The following is a description of a gene set: species: Homo sapiens In otosclerosis, a callus of bone accumulates on the stapes creating a partial fixation. This limits the movement of the stapes bone, which results in hearing loss. Human Gene Set: HP_OTOSCLEROSIS Otosclerosis, and this is the list of marker genes: FOXL1 (forkhead box L1), COL1A1, IDS, SMARCA4, COL1A2, GDF6, BPTF, PSMD12